The following is a description of a gene set: studied in species Mus musculus Mouse Gene Set: REACTOME_DOWNSTREAM_SIGNALING_OF_ACTIVATED_FGFR4 Downstream signaling of activated FGFR4, and this is the list of marker genes: Ptpn11, Fgf1, Kras, Fgf17, Gab1, Fgf15, Fgf20, Shc1, Frs2, Klb, Plcg1, Fgfr4, Fgf8, Pik3r1, Sos1, Fgf16, Fgf9, Frs3, Hras (Harvey rat sarcoma virus oncogene), Fgf2, Grb2, Fgf18, Fgf4, Fgf6, Pik3ca, Fgf23